Given this list of marker genes TPM3, ZNF703, BCL2L2, BTG1 (NCBI Gene Id 694), NOSTRIN, TMEM53, FBXL19-AS1, BDNF, ATF3, TNKS1BP1, DLG3, WFDC3, MIR137HG, CDK14, NHS, BNC1, CA9, TGFBR1, BMP5, HDDC2, PTCH2, FLOT1, TEAD1, BCL9L, NOVA1, GRAP2, TGFB3, FOXA1, NRG1, ICAM1, PTCHD1, GATA1, ELP4, WT1-AS, PPP1R12A, EBF1, MAP2K6, DLG2, PCDH17, SEMA3A (NCBI Gene Id 63232), MOB3C, UBE2H, SELENOI, EME1, TRPM3, VPS37B, LUC7L, FLNC (filamin C), MUSK, OFCC1, CLEC4D, MCTS1, LIN9, PPA1, CDH16, PRG4, CCDC140, WDR54, SKIL, ZIC3, MBNL1, TIGD3, UBAC2, STIP1 (NCBI Gene Id 10963), P4HA2, PPID, CD74, SLIT3, MRPS6, DOCK4, IER3, RBM14, WBP1L, BATF, DHH, LMAN2, WWOX, LMO4, SFXN2, PRRX1, ACTN3, DNTTIP1, PPARGC1B, BZW1, ZEB2, RFX4, BTF3P11, OSBPL9, HIRA, ANKRD40CL (ANKRD40 C-terminal like), EGLN2, RUNX1, SYNPO2L, WDR81, PDHA2, CP, RALYL, CELF4, VWF, GATA3, MEGF8, ALKBH6, RGS3, PRKCH, ADRA2C, LUZP1, HOXC4, PAX3, CHRND, INHBA, NKX2-8, HOXA5, S1PR2, THAP7, TNFSF10, SOCS2, THAP7-AS1 (THAP7 antisense RNA 1), UPK2, KANSL3, ASIC2, GPR85, RANBP3L, ZNF436-AS1, RFX5, KMT5A, BRS3, ETV6, PTPN6, SZRD1, SERPING1, RREB1, HNF4G, POLR1G, AKT1S1, HOXB9, FOXN3, UBE2C, ZDHHC24, LAYN, INTS10, CRYGB, IMMP1L, SP7, B4GALT5, SPATS2 (spermatogenesis associated serine rich 2), ARL3, PTK7, LENG9, PRRG4, CHRDL1, MIR22HG, NUDT16L2P, SLCO3A1, IRX3 (NCBI Gene Id 79191), SP6, BLVRB, LRRC37A11P, GTPBP1, CACNA2D3, MRPL27, AMD1, PRDM1, KCNIP2, METAP1 (NCBI Gene Id 23173), YPEL4, MRPL40, HBEGF, CHMP4B, MYADM, LRRK1, ENTREP3, WBP1, PHACTR3, GSC, ARHGAP12, NRP2, TRIB1, ETV5, ZMYND8 (zinc finger MYND-type containing 8), SOX14, EGR3, NTRK1, SRPX, NUFIP2, OTOP2, FAM81A, TBC1D17, TBXT, SPRY2, PPARD, EMX2, TLE3, TAL1, RNF34, PLAC1, SLC26A7, NFATC1, INO80, EN1, KCNA2, MYF6, MEIS2, USH1G, OIT3, CA6, HAVCR2, CRLF1, FEZ2, CHML, CHD2, CCN1, NEDD4, RNF220, MYO18B, ITGB4, MIDEAS, SPTBN4, TUG1, SLITRK5, ITGA7, UNC45B, RCL1, CD274, ESAM, SNCAIP, RNF182, EMC3, TWIST1, HOXC11, CHRNA2, CHN2, FBXO36, FGF10, CALCOCO1, JAG1, AMOTL1, SFTPC, FGF14, A2M, SLC1A4, FANCI, TSEN54, TMPRSS5, GJB1, BATF3, WASHC4, HOXB2, TENT5C, TBCC, TAF5, HOXD3, SNHG29, PPP1R9B, HHEX, GNB4, MOSPD1, KDM4B, GRIA1, DDX23, XPR1, BET1, ATP2C1, CASKIN2, LDB1, here is a description of the gene set: species: Homo sapiens Genes having at least one occurrence of the motif CTGGAACTMAC in the regions spanning 4 kb centered on their transcription starting sites. This matches the PAX2 transcription factor binding site V$PAX_Q6 (v7.4 TRANSFAC). Human Gene Set: PAX_Q6